The following is a description of a gene set: Human Gene Set: HP_ABNORMAL_FEAR_INDUCED_BEHAVIOR An abnormal fear-induced behavior includes observable actions. This behavior is characterized by abnormal responses to fear or abnormal fear levels. Examples of such behavior include avoiding fear-inducing situations. species: Homo sapiens Abnormal fear-induced behavior, and this is the list of marker genes: EP300, USP8, FIG4, GM2A (NCBI Gene Id 2760), AIP, CREBBP, ALAD, MECP2